The following is a description of a gene set: Microcephalic sperm head Human Gene Set: HP_MICROCEPHALIC_SPERM_HEAD Decreased size of the head of sperm. species: Homo sapiens, and this is the list of marker genes: CFAP69, IQCN, USP26, CFAP91, TTC29